Given this list of marker genes CYCS, TOMM40, PAICS, PRMT1, BZW2, SNRPD1, GNL3, NCL, NOP58, EBNA1BP2, EIF4EBP1, FABP5, ATP5MC1, PPA1, NOP16, LDHB, MRTO4, MRPL3, RUVBL1, NHP2, CCT2, C1QBP, DCTPP1, SLIRP, NIFK, PA2G4, RAN, NOLC1, CMSS1, ODC1, LDHA, DDX21, GPATCH4, HSPD1, MRPL12, RANBP1, DKC1, PHB1, CCT5, NME1, ENO1, SRM, HSPE1, MYC (NCBI Gene Id 731404), PNO1, NOP56, FKBP4, TIMM13, EIF5A, DCAF13, here is a description of the gene set: Genes upregulated in subsets of cells of a given type within various tumors species: Homo sapiens In this study, an extensive analysis was conducted to define meta-programs (MPs) capturing intra-tumor heterogeneity across a spectrum of tumor types. The approach utilized non-negative matrix factorization (NMF) to analyze each cell type separately within individual tumor samples. This involved the analysis of malignant cells, macrophages, fibroblasts, endothelial cells, epithelial cells, T-cells, and B-cells. NMF was executed with varying parameter values (K=4, 5, 6, 7, 8, 9), thereby generating 39 programs for each cell type per sample. Each NMF program was summarized by the top genes based on NMF coefficients.\nRobust MPs were then delineated for each cell type using a set of stringent criteria, including recurrence within the same tumor, similarity to programs in other tumors, and non-redundancy within a tumor. Subsequently, these robust NMF programs were clustered (per cell type) based on Jaccard similarity, leading to the identification of MPs associated with each cell type.\nTo enhance the quality of the MPs, a refinement steps were undertaken, involving the removal of MPs suspected of reflecting low-quality data (with an overrepresentation of ribosomal proteins or mitochondrial-encoded genes), single-study inclusion, or similarity to miss-annotated cell types. from publication Gavish A, Tyler M, Greenwald AC, Hoefflin R, Simkin D, Tschernichovsky R, Galili Darnell N, Somech E, Barbolin C, Antman T, Kovarsky D, Barrett T, Gonzalez Castro LN, Halder D, Chanoch-Myers R, Laffy J, Mints M, Wider A, Tal R, Spitzer A, Hara T, Raitses-Gurevich M, Stossel C, Golan T, Tirosh A, Suvà ML, Puram SV, Tirosh I (PMID 37258682) Human Gene Set: GAVISH_3CA_MALIGNANT_METAPROGRAM_20_MYC